The following is a description of a gene set: Reactome Pathway: Transport of Mature mRNAs Derived from Intronless Transcripts This event has been computationally inferred from an event that has been demonstrated in another species.<p>The inference is based on the homology mapping from PANTHER. Briefly, reactions for which all involved PhysicalEntities (in input, output and catalyst) have a mapped orthologue/paralogue (for complexes at least 75% of components must have a mapping) are inferred to the other species. part of: Transport of Mature Transcript to Cytoplasm species: Mus musculus electronically inferred by orthology from the curated human pathway, and this is the list of marker genes: Nup58, Cpsf3, Nup155, Nup210, Nup93, Wdr33, Alyref, Nup54, Cpsf1, Seh1l, Nup42, Nup133, Nup85, Ndc1, Nup205, Slbp, Rae1, Fip1l1, Aaas